The following is a description of a gene set: Mouse Gene Set: REACTOME_CHROMATIN_ORGANIZATION species: Mus musculus Chromatin organization, and this is the list of marker genes: Kat6a, Sap30, Ncoa1, Gatad2a, Hdac1, Phf2, Kdm7a, Setd3, Padi3, Msl2, Prdm9, Gps2, Rbbp4, Bcl7b, H3c8, Rbbp5, Kansl3, H3c1, Prmt1, Smarce1, Nfkb1, Kdm4c, Ing5, Cdk4, Kdm5a, Kdm1b, H3c2, Bicra, Bcl11a, Tbl1xr1, H3c11 (H3 clustered histone 11), Kmt2b, H3c4, Jade3, H4c1, Kdm6a, H2ac21, Riox2, H4c8, Smyd3 (SET and MYND domain containing 3), Tbl1x, H2bc13, Smarcd3, H2bc24, Ss18l1, Uty, Carm1, H3c3, Kat8, Actb, H2ac7, Smarcb1, H2bc26, Rbbp7, Suds3 (NCBI Gene Id 71954), Kdm4b, H2bc1, H4c17 (NCBI Gene Id 100041230), Arid5b, Brpf1, Kdm4a, Ash1l, H3c15, Padi1, Chd3, Suv39h1, Kmt5a, H2ac12, H2bc9, Kansl1, Kat6b, Ccnd1, Prmt3, H2ac4, Arid1a, Padi4, Suv39h2, Aebp2, Ing4, Jmjd6, Msl3, Bicral, Bcl7a, H2ac6, H2ac15, Smyd2, Wdr5, H2ac10, Phf8, Hat1, Bcl7c, Sap30l, Setd1b, Suz12, H2bc4, Pax3, Actl6a, Kdm2a, Ash2l, Nsd1, Prdm16, H2bc3, Ehmt1 (NCBI Gene Id 77683), Hmg20b, Kmt2d, Hdac10, Mcrs1, Hdac8, H2bc6, H2bc21, Arid4b, Rps2, Dot1l, Brwd1, Dpf3, Padi2, H2aj, H2ac22, Ehmt2, Rela, Jade2, H2ac19, Kdm3b, Kmt5c, H2ac20, H3c14, H2bc7, Ss18, Phf20, Padi6, Prmt7, Arid4a, Setd6, Phf21a, Mta2, Meaf6, Atf7ip, Mbd3, Hdac3, H4c12, Smarcd2, H3c7, Kdm5c, Atf2, Brd9, Kmt5b, Setd1a, H2ac13, H3c6, Kansl2, Kdm6b, Pbrm1, H2ac24, H3c10 (H3 clustered histone 10), Smarcc1, H2bc12, Prmt6, H3c13 (H3 clustered histone 13), H4c11, Kdm1a, Brms1, Actl6b, H2bc14, Kdm3a, Mta3, Ogt, H2ac18, H4c14, Dnmt3a, Kmt2a, Ncoa2 (nuclear receptor coactivator 2), Brpf3, Rcor1, H2bc8 (NCBI Gene Id 319181), Coprs, Nsd3, H4c16, Rest, H2ac8, H2bc22, Nfkb2, Kat7, Chd4, Brd7, H2ac23, Jade1, H2bc15, Smarca4, H4c3, Ncor2, Eed, H2bc11, Kdm5d, Bcl11b, Ezh2, Hcfc1, Setdb2, H4c6, H2ac11, Brd1, H4c4, H2ac1, H4c2, H2bc23, Kdm5b, H4c9, H2ac25, Mta1, Wdr77, Kdm4d, Setdb1, Smarcc2, Kdm2b, Gatad2b, Prmt5, H2bc18, H4c18, Smarcd1, Setd7, Nsd2, Setd2, Msl1